The following is a description of a gene set: species: Homo sapiens from publication Yevshin I, Sharipov R, Kolmykov S, Kondrakhin Y, Kolpakov F (PMID 30445619) Human Gene Set: ZSCAN2_TARGET_GENES Genes containing one or more binding sites for (ZSCAN2) in their promoter regions (TSS -1000,+100 bp) as identified by GTRD version 20.06 ChIP-seq harmonization., and this is the list of marker genes: LINC02363, SLC25A53, F2, FGL1, PKDCC, NDUFA4, C6orf62, STAM, CHASERR, NEK2, RNU5B-1, SPHK2, ISG20, GORAB, SNF8, LNCATV, CNPY2, RAB31, CNPY2-AS1, IGF1R, MTND4P7, H4C2, CEP76, ST13, GLT8D1, PSMG2, ZFHX3, ETV4, SART1, FGA, FUT5, PCBP1-AS1, RPL23AP7, COMT, GGNBP2, MOGAT1, ALDH3A2, DPH6, MED29, CHN2, MON2, TTLL9, RNU6-813P, H2BC3, GDF15, H1-5, GOSR2-DT, UPF2, MBNL2, LRR1, GLE1, PROSER1, POR, FKBP7, GOSR2, ENSG00000260830, RNVU1-27, PSMD12, BABAM2, CCT4, GSTZ1, ABCC3, LONP2, DDX39B-AS1, ZNF782, NR1D1, MST1P2, LMAN2, LINC01016, SMAD7, SART3, ZNF576, H3C12, MIR22HG, DCTN1, RWDD1, RNF139, FAM53C, ANAPC7, SPRED2, RPS10, MRTO4, RNU6-781P, TBL1X, MIR6811, RDH10, BLCAP, SLX4IP, MARCHF7, MRPL3, SETD4, KLHDC10, STT3B, PAK1IP1, FAM222B, UBE2I, UBQLN1-AS1, PCM1, RNF25, NAP1L1, MIR1302-4, SNORD95, ST3GAL1, LINC01124, DMXL1, POMT2, RCC1L, DNMT3A, SNX5, RPL36A, H4C3 (H4 clustered histone 3, NCBI Gene Id 8364), HDAC8 (histone deacetylase 8), FARSB, JMJD4, ZNF165, BTK, TIA1, EEPD1, STARD10, PPP1R3D, LYSMD1, MRPL38, LRMDA, H4C5, RPL7L1, SREK1, IPO13, ATG13, HMCN1, MACF1, CLASP1, PSMD14, TPRKB, H2BC6, SEC11C, SERPINB9P1, EFTUD2, DECR2, ZFAT, AMBP, NDC1, NHP2, MRPL11, WDR47, RNU6-563P, VAC14, FAM187A, AIMP1, ARHGAP11A, APEX1, H2BC15, SNORA21, MIR497HG, HP, MIR5707, TTC3, RNF139-DT, EIF4ENIF1, DOCK6, THADA (THADA armadillo repeat containing), DPEP2, NANOGP1 (Nanog homeobox pseudogene 1), TLE3, RAD17, TFF1, CCDC150, INTS9, CDKN2AIP, AP3M1, NUFIP2, PIGK, MIR4259, TGFBI, ZNF227, PAF1, NSUN5, TMEM106A, HSPA8, RPL18, MRM1, FBXO8, H2AC8, KLRK1, RPS29, TOMM40, SFSWAP, H4C11, EMC1, TRMT11, LAPTM4B, FAM162A, BTNL12P, HS2ST1, CFAP95, TSNAX, MED18, HPR, STXBP5-AS1, ALG2, IFT43, SLC16A7, ACKR2, H4C12, GTF2B, ZFAND4, NCOR1, DECR1, ATP6AP1L, DDX23, VARS1, H1-2, GARS1-DT, THSD4, SMG6, CTR9, LRP10, GABPB1-AS1, MAPKAPK5-AS1, APOH, ESPN, SEMA3C, BATF, ZNF79, HAL, TM4SF1-AS1, IQCG, CEP44, N4BP2L2, SEPSECS-AS1, ADK, LINC02428 (NCBI Gene Id 101929448), RAD51B, STK40 (NCBI Gene Id 83931), CDC73, DYNC1LI2, CDC25C, MBD5, ZNF83, ZNF891, GORAB-AS1, CYP1A1, POLR3F, ZNF169, HSPA1B, TRIM41, DOK7, STC2, CCNL1, TJP1, RNF43, BUD31, C1QTNF6 (NCBI Gene Id 83847), CPLX2, H2AC7, CCNO, TMT1A, H4C8, SCNM1, EXT1, UGT2B10, PSMD1, MRPS35-DT (MRPS35 divergent transcript), ACYP2, ATOSA, PDHX (pyruvate dehydrogenase complex component X), TAOK3, DGKZ, VSNL1, DENND10, RNU2-63P, RPS2P32, SUGP2, RPL37A-DT, PPIL3, LINC00663, JAG1, UROD (uroporphyrinogen decarboxylase), GARS1, PRKAB1, SRD5A1, LINC01101, ZNF321P, OARD1 (NCBI Gene Id 221443), MAPKAPK5, MACC1, SRSF11, MSMO1, SNHG32, OSGEP, TM9SF1, SERBP1, RABGGTB, DYNC2I2, GGA3, RO60, IL1RN, SNRNP35, KRR1, BRF1, MYOF, ZNF37A, LINC03037, NR0B2, ACTRT3, H2AC20, MIR3189, ZRANB2-DT, ZGRF1, EIF2S2P5, LINC03064, RPL7, BNIP1, ITK, RNA5SP21, SORBS3, FAM3B, CENPL, PRDM10, IER3-AS1, SSUH2, TNS1, ACADM, WWC1, CNTRL, LINC02237, SLC5A6, ASGR1 (asialoglycoprotein receptor 1, NCBI Gene Id 432), DZANK1, ANXA9, ACTR10, EFNA1, C4BPB, LFNG, DNAJB13, RPS27L, ZNF37BP, DDX47, ADGRF4, H2BC13, ZNF585B, MGME1, SLC35B1, FIS1, LINC00963, UBQLN1, NCLN, SLC25A21 (solute carrier family 25 member 21), UBE2K, ZNF131, PNO1, SNHG7, CDK5RAP2, COA6, HYAL3, CCDC77, AFG3L1P, AADACP1, ENSG00000187951, SLCO4A1-AS1, NCAM2, CFAP45, UVRAG, FERRY3, TBP, DNAL4 (dynein axonemal light chain 4), STK36, H2AC6, MOGAT3, GADD45GIP1, SPATA4, AP1G2, LYZ, NME1, ZBTB6, CDK5RAP1, COX7A2L, NEU1, TMED1, CAPRIN1, INHA, GGCTP1, H2BC11, NSUN2, TOE1, SMG1P2, CCNO-DT, LARP7, DARS2, TACR1, SLC44A2, RABL2B, TMCO4, EXOSC8, RREB1, CHMP3, ZNF56P, LRRC40, MTREX (Mtr4 exosome RNA helicase), AOC4P, RRAGC-DT (RRAGC divergent transcript), NKX3-2, TOMM20L-DT, ANKLE2, BCKDHA (NCBI Gene Id 593), NAA80, CCDC115, ZNF235, RACK1, MGC32805, VPS26A, ZSCAN5A, RN7SL621P, GLB1, RPS12, CSPP1, NKD1, COMMD1, SERPINA11, DNAJC5B, SRI, PFDN5, HSD17B2, RPS23, MIR5695, EDEM2 (NCBI Gene Id 96814), RRBP1, ERCC1, PKLR, ADAT2, AMT, HISLA, RPL21, PLSCR4, DNAAF3, CYP4F12 (cytochrome P450 family 4 subfamily F member 12), DGAT1, ENSG00000260288, CROCCP2, HAVCR2, MNAT1, MATCAP2, SNORD118, PCGF5, DDX31 (NCBI Gene Id 64794), TMEM69, RPS20P25, FGGY, MARK4, PSMB1, CAPZA2, SLC30A6 (solute carrier family 30 member 6, NCBI Gene Id 55676), BAG6, GOLGA5, TIMM9, ARHGAP11A-DT, UGGT1, COX7C (NCBI Gene Id 1350), CACTIN, CCDC43, DDX60, MIR378A, ATP6V1C1, TIMM22, SPCS1, SMARCE1, LINC01843, TAF6L, H2AC5P, MIGA1, CLHC1, CFB, SEPSECS, H1-4, CASP4, MEPCE, LSM5, IMP4, ZNF184, ABHD2, POLR2E, ENSG00000254337, RPL35A, FAM133B, NDUFA10, UCHL5, NHLRC3, ARF6, TM4SF1, NIF3L1, HMOX2, LINC01588, VTN, CENPA, H2BC17, C6orf89, SNRPF, SMIM2-AS1, CFAP107, VNN3P, GLRX2, SNORD101, HSPA9, SEC24D, SUN2, ALKBH5 (NCBI Gene Id 54890), SERPINA1, ACTN4, MIR4645, VKORC1, SUCLG1 (succinate-CoA ligase GDP/ADP-forming subunit alpha), H2AC14, LMBR1, SLC26A11, PES1, SH3YL1, RPL7P30 (ribosomal protein L7 pseudogene 30), SUPV3L1, VPS45, CENPI, MRPS7, WDR3, NRDE2, TOMM20, BRPF1, SMG1, CYB5A, DHX29, TMEM147, CPVL, H2BC21, ATP6AP1-DT, HNF1A, RABGAP1L, SUPT16H, PCLO, PEX3, CELSR1, G6PC1, VDAC2, SYCE2, PCF11 (PCF11 cleavage and polyadenylation factor subunit), TELO2, ARMC8, ANGPTL8, DSCAM-AS1, ENSG00000233461, ENSG00000228697 (NCBI Gene Id 101928565), TXNP5, DYNC1LI2-DT, SRRM5, TMEM147-AS1, ENSG00000267288, APOA2, HNMT, ZRANB3, PTCD2, H2AC21, FBXO39, LINC01770, FARS2, RPL39P40, SARM1, SLC30A6-DT, H2BC14, NHLRC2, SORT1, UPF3B, PRKCI, DNAAF10, EIF4H, COA6-AS1, ZNF335, POU2AF1, TTC33, HARBI1, HNRNPLL, RRP7A, MIR205HG, RBKS, UFM1 (ubiquitin fold modifier 1), CMTR1, PCBD2, NLRP7P1, PGC (NCBI Gene Id 5225), PSMA1, MUTYH, ZNF343, ZNF609, GTF3C3, SMG1P5, SCARNA2, IRS1, TRAP1, FXN, H4C1, EHD1, TANK-AS1 (TANK antisense RNA 1), OBSL1 (NCBI Gene Id 731094), PPP1R12B, CCNB1IP1, UGT2B27P, TOMM20L, EXOC3L4, ERC1, VPS50, INTS5, SLC35E3, ZNF81, TBCK, RPS24, MRPL9, H2AC11, PTGES2-AS1, ABCD2, HECTD3, KIAA0319, GREB1, OAZ3, MRFAP1L2, SEC24A, TMEM109-DT, NIT2, ZBED3-AS1 (NCBI Gene Id 730772), TSN, ZNF354B, PUS10, CENPC, SKP1, NKX6-1, RAPGEFL1, ACSL6, XRN1, H2BC8 (H2B clustered histone 8), HMGCS1, FRA10AC1, HS1BP3-IT1, ZSCAN5A-AS1, COASY, MRPL45, SEPTIN7P2, SGSH, MRPS35, TAF9, DLC1, VCF1, GPBP1L1, TMPPE, SMG1-DT, ENSG00000212229, KCTD3, SELENOF, COMMD7 (COMM domain containing 7), SLC35A1, BICRA, H2AC17, C9orf43, LINC01881, FAM13A, CLRN2 (NCBI Gene Id 651058), AMBRA1, FLOT1, SLC45A4 (NCBI Gene Id 57210), SLC51B, MDP1, RPL23AP82, RNU5D-1, RNU6-745P, VTI1B, H2BC18 (NCBI Gene Id 729127), XPNPEP3, PAWR, SF3B3, MIX23, CARMIL1, TMEM109, HSPH1, H4C16, HOXA-AS2, IRGQ, CENPBD1P, H2BC4, C2orf42 (chromosome 2 open reading frame 42), GRB7, DNMT3B, SLC39A11, SLC25A30, FBXO27, MGP, TBX2-AS1, GALK1, FOXN3, TMED10, TMEM41A, CLIC1, SLC38A11, DTNA, DCAF11, ZC4H2, IFT70B, CS, MIR5684, SMLR1, SETD1A, MED7, SLCO4A1, FAM120AOS, TTC8, RGS17P1, GDAP2, FAM178B, RXYLT1, LINC02918, PDAP1, GPRC5C, ZNF234, RPL23, RPL36A-HNRNPH2, SULT6B1, OCLN, RAB29, SMC2, ARL1, NXN, MIR4437, SP5, SLCO2B1, LINC02832, ATP5MG, EFNB1, CHROMR, CEP350, PIN4, RNASE11 (NCBI Gene Id 122651), NOP53, KLHDC2 (kelch domain containing 2), RARA (retinoic acid receptor alpha), POT1, ST8SIA4, PCK1, CCN5, SLC25A19, LBX2-AS1, ARHGAP11B-DT, CMSS1, NMRAL1, HADHA, AMZ2, RGN, GPR160, NME1-NME2, ENSG00000282793, GLUD1P3, ZNF383, NUDT13, GEMIN4, H2AC13, H2BC9, NRP1, AHSG, R3HDM1, EIF2S3, PRRC2C, LYRM4, SCRIB, PPP1R37, RLIG1, DPH6-DT, ASPSCR1, RAD52, ZNF565, KANSL3, LINC01820, SNORA14B, ICE1, NUCKS1, CFAP95-DT, GPX1, CTDSP1, NELFA, KAT2B, EPRS1, RAB42, APIP, DCLRE1A, RPN1, PDE12, LINC02747, TRIB1, RPL7P41, DHRS2, KDM1A, ORC4, PEBP1, NME6, XRCC1, AGT, ZZEF1, CHD8, RBBP5, INHBE, POLR2K, ZNF112, C6orf52, CLTC, C3, SLCO2A1, TSNAX-DISC1, MED27, SMAD3, GEMIN7, TAF1, STAT6, RPS27A, RPL39P5, PTGES2, NVL, CA12, DNPEP, H4C4 (NCBI Gene Id 8360), MRPS5, SELENOP, GLTPD2, AK6, DDX39B, SNORD48, SNORD45C, ENSG00000239137, RABL2A, FKBP1A, GTF3C4, NUP85, RPRD1B, MTNAP1, ATRAID, NUP205, HCG27, SNAP47, VWA7, SPHK1, HMGCR, PSMC3, SEPTIN7P3, ZNF285, DZIP1 (DAZ interacting zinc finger protein 1), SEC61B, BICRA-AS2, DNMT1, STAM2, RBM23, RNU11 (RNA, U11 small nuclear), EXOSC5, STAM-DT, LPCAT3, FKBP4, APOA1, SMARCAL1, TOP2A, BOLA1, COG4, AXDND1, ZNF813, PI4KB, HMBOX1, HEY2, GHITM, CCL20, VMP1, DBR1, MAPKAP1, C19orf48P, TXNRD2, RNU4-2, ZBTB25, ZKSCAN3, NAT10, NSMF, ALG5, FMN1, ZNF224, CCDC103 (NCBI Gene Id 388389), REXO1, IGSF23, MIA3, SERPINA10, CES1, HADHB, RAD51AP1, ARSB (NCBI Gene Id 411), C8A, ZRANB2, MKRN2, RPS10-NUDT3, VAX2, PCBP1, TF, H2BC7, APOC3, ACAA1, COL18A1-AS2, SUDS3, RPL37A, C19orf38, FABP1, HSD17B3-AS1, UTRN, RASSF4, LDLRAD4 (low density lipoprotein receptor class A domain containing 4), KIF5B, PDZK1, MGST2, NFE2L2, HMGXB3, HPN, SEPTIN8, POLE3, BDH1, KIAA0586, RHOBTB3, SNRPF-DT